Given this list of marker genes Pafah1b1, Mrtfa, Nectin4, Zfp759, Slc9a6, Homer1, Fasn (NCBI Gene Id 353049), Mllt10, Cd27, Nphs1, Nr0b2, Ficd, Agtrap, Ifit1bl2, Nanos1, Ngp, Dcaf17, Dmpk, Prkdc, Sypl2, Atxn2l (ataxin 2-like), Oas2, Zfp729b, Ucp3, Wnt9b, Tmem254, Fam222b, Ksr2, Zfp609, Rps23rg1, Gm14137 (NCBI Gene Id 639597), Ttll12 (tubulin tyrosine ligase-like family, member 12), Gabra4, Cd40, Garin1a, Slc35c1, Hecw1, Myo1c, Aar2, Ggt5, Fubp3, Rgs7bp (regulator of G-protein signalling 7 binding protein), Krtap6-2, Khdrbs2, Lyrm1, Ly6a, Rasd2, Tfap4, Itgae, Esam, Amdhd1, Zfp426, Fcgr3, Tlk2, Marchf9, Lin52, Syn1, Gss, Slc26a1 (solute carrier family 26 (sulfate transporter), member 1), Cap1 (cyclase associated actin cytoskeleton regulatory protein 1), Slx4ip, Vdac1, Adcy9, Nufip1 (NCBI Gene Id 27275), Pbx1, Mrpl10, Klk7, Ano3, Gpr33, Doc2b, here is a description of the gene set: species: Mus musculus from publication Chen Y, Wang X (PMID 31504780) Mouse Gene Set: MIR_5621_5P Genes predicted to be targets of miRBase v22 microRNA mmu_miR_5621_5p in miRDB v6.0 with MirTarget v4 prediction scores > 80 (high confidence targets).